Given this list of marker genes Pot1b, Fgfr4, Pkib, Ddx39b, Nox4, Cct5, Cyp1b1, Pak3, Mapk1, Cct8, Cct3, Rfc2, Pcna, Terc, Map2k7, Wrap53, Cct7, Xrcc5, Rfc3, Pot1a, Rgcc, Dscc1, Camk2d, Polg2, Arrb2, Atm, Cct6a, Nek7, Fbxo4, Tnks, Egf, Ctnnb1, Gch1, Pdgfb, Htr2a, Ptges3 (prostaglandin E synthase 3), Hnrnpd, Gsk3b, Nfatc1, Prkcq, Ptk2b, Gfer, Hgf, Wnt3a, Chtf8, Rfc5, Cct4, Atr, Cct2, Pnkp, Ccna2, Tcp1, Smoc2, Chtf18, Fgf2, Crhr2, Nek2, Tnf, Aurkb, Mapk3, C3ar1, Dkc1, Mapkapk5, Acd, Map3k4, Parn, Mapk15, Rfc4, Hmbox1, Vegfa, Prkd2, Pdgfrb, here is a description of the gene set: species: Mus musculus Mouse Gene Set: GOBP_POSITIVE_REGULATION_OF_DNA_BIOSYNTHETIC_PROCESS Any process that activates or increases the frequency, rate or extent of DNA biosynthetic process.